Given this list of marker genes Leo1, Emc4, Ccser2, Sema6d, Ccng1, Lemd3, Zmynd19, Cmah, Cyp26b1, Fam229b, Dio2, 1700066M21Rik, Ptprk, Gbx2, Nopchap1, Adra2a, Yes1, Xpot, Crispld1, Tent4b, Upb1, Zeb1, Csde1, AW554918, Glul, Epha5, Pafah1b1, Syt1, Zyg11b, Matn3, Wdr33, Apoo (NCBI Gene Id 73714), Dyrk1a, Rnf19a, Cep57, Slc8a1, Dclre1c, Gm14322, Pcdh17, Wif1, Vezf1, Trim33 (NCBI Gene Id 99609), Cdh7, Snx30, Tpbg, Zfyve19, Mfsd9, Pcmtd2, Klhl15 (NCBI Gene Id 76150), Crebrf, Thoc1, Dact1, Arih1, Pcdh7, Pid1, Camk2b, Zfp131, Pcgf5, Psg23, Scaf8, Svil, Cdc42se2, here is a description of the gene set: Genes predicted to be targets of miRBase v22 microRNA mmu_miR_299b_5p in miRDB v6.0 with MirTarget v4 prediction scores > 80 (high confidence targets). Mouse Gene Set: MIR_299B_5P from publication Chen Y, Wang X (PMID 31504780) species: Mus musculus